Given this list of marker genes Akr1c20, Akr1c18 (NCBI Gene Id 105349), Akr1c6, Akr1d1, Akr1c14, Akr1cl, here is a description of the gene set: species: Mus musculus Catalysis of the reaction: a 3-oxo-5beta-steroid + NADP+ = a 3-oxo-Delta(4)-steroid + H+ + NADPH. The enzyme from human efficiently catalyzes the reduction of progesterone, androstenedione, 17alpha-hydroxyprogesterone and testosterone to 5beta-reduced metabolites; it can also act on aldosterone, corticosterone and cortisol, but to a lesser extent. The bile acid intermediates 7alpha,12alpha-dihydroxy-4-cholesten-3- one and 7alpha-hydroxy-4-cholesten-3-one can also act as substrates. Mouse Gene Set: GOMF_DELTA4_3_OXOSTEROID_5BETA_REDUCTASE_ACTIVITY